Given this list of marker genes IL6ST, IFITM1, MAL, IL7R, RPL4, TMC8, RPS23, PIM1, RPL13, LDLRAP1, RPL8, RPS20, TXNIP, RPL19, TRABD2A, RPL34, SEPTIN1, TRAF3IP3, RPS13, RPS27, LEF1, TESPA1, SPOCK2, RPS19 (ribosomal protein S19), FCMR (NCBI Gene Id 9214), MYC, SATB1, RPL28, RPS15, RPS28, RPL10, RPL10A, RPL23, RPL18, LCK (LCK proto-oncogene, Src family tyrosine kinase), CCR7, RPS2, RPL23A, RPL13A, RPL27 (ribosomal protein L27), ITK, RPL35A, RPL41, EEF1A1, RPL12, RPL27A, RPL30, RPL26, RPL11, RPL14, RPS21 (ribosomal protein S21), RPL39, RPLP0, LDHB, RPL32, CMPK1, NELL2, RPS8, SUSD3, NOSIP, RPL29, PCED1B, TNFRSF25, PASK, PRKCQ-AS1, RPS14, BCL11B, SNHG5, PIK3IP1, EPHX2, CHMP7, RPS7, ADTRP, RPS3A, RPL18A, INPP4B, RPS16, RPLP2, SERINC5, CD3E, RPS6, RPL5, DGKA, RPS29, PRKCA, FHIT, THEM4, NDFIP1, RPL7, STMN3, CD27, AAK1, RPS5, PIM2, RPS12, OXNAD1, PCED1B-AS1, TC2N, RPS15A, CD6, RPLP1, RPL24, SELL, IL32, RPL13AP5, RPL37, LINC00861, RPL15, NPM1, SNHG3, GIMAP4, SARAF, RPS3, RPL6, TCF7, RCAN3, RPL38, RPL3, RPL35, TLE5, CD3D, RPL31, TRAT1, DPP4, AQP3, RPS27A, TXK, RPL37A, ABLIM1 (NCBI Gene Id 3983), EEIG1, GIMAP7, RPL36, here is a description of the gene set: studied in species Homo sapiens from publication Travaglini KJ, Nabhan AN, Penland L, Sinha R, Gillich A, Sit RV, Chang S, Conley SD, Mori Y, Seita J, Berry GJ, Shrager JB, Metzger RJ, Kuo CS, Neff N, Weissman IL, Quake SR, Krasnow MA (PMID 33208946) Human Gene Set: TRAVAGLINI_LUNG_CD4_NAIVE_T_CELL